The following is a description of a gene set: from publication Chen Y, Wang X (PMID 31504780) Genes predicted to be targets of miRBase v22 microRNA mmu_miR_153_3p in miRDB v6.0 with MirTarget v4 prediction scores > 80 (high confidence targets). Mouse Gene Set: MIR_153_3P species: Mus musculus, and this is the list of marker genes: Sphk2, Taf5, Dmd, Pou4f1, Mdn1, Fhip1a (FHF complex subunit HOOK interacting protein 1A), Smpdl3a, Gatm, Smarca5, Gnpda2, Spty2d1, Rpl22, Nfia, Trp53inp1, Ankrd40, Clgn, Garem1, Nudt4, Zfp704, Nptn, Wwp1, Inhbb, Cbfb (NCBI Gene Id 12400), Ptpn3, Fam168a (family with sequence similarity 168, member A), Kmt2b, Kansl1l, Kmt2a, Rock1, Acap3, Zfp385c, Clcn5, Lamp1, Niban2, Dennd1b, Ttn, Nfe2l2, Ror1, Frmd5, Sptbn4, Ahr, Kdm6a, Eeig1, Gnai3, Celf6, Rttn, Appl1, Gab1, Ube2k, Snai1, Socs2, Ing2, Zhx1, Ddit4, Neurod1, Or4n5, Ago1, Lamc1, Kcnq4, Gmcl1, Fam168b, Nhsl3, Zfp521, Mov10, Ckap4, Pclo, Grb2, Vamp2, Trp53inp2 (transformation related protein 53 inducible nuclear protein 2), Zfp654, Atad2b, Tes, Robo2, Cap1, Mosmo, Sun2, Ctdspl2, Sco1, Adam23, Kif7, Sbno2, Grip1, D430041D05Rik, Ebf2, Tpk1, Rabgap1, Kcna6, Lhfpl6, Rps6ka5, Atp8a1, Txndc11, Zbtb2, Jag1 (NCBI Gene Id 170642), Sigmar1, Rest, Cacna1b, Ybx1, Kcna1, Kctd5, Foxd1, Ski, Zdhhc2, Atosa, Gxylt2, Epha4, Ptbp1, Dcaf12, Me1, Tagln3, Zcchc2 (zinc finger, CCHC domain containing 2), Gm527, Daam1, Fam210b, Fyn, Rps6kb1, Osbpl6 (NCBI Gene Id 99031), Sgms2, Slc4a4, Foxo1, Ttc28, 1600012H06Rik, Rab12, C2cd2, Mknk2, Hgsnat, Lhx9, Arl13b, Six4, Satb1, Fzd3, Actn4 (NCBI Gene Id 97354), Ppm1d, Neurod6, Amph, Otx2 (NCBI Gene Id 218991), Ube2w, Tor1aip1, Casp12, Arid1a, Fbxo33, Sertad2, Sestd1, Unc5c, Fam184b, Utrn (NCBI Gene Id 22288), D030056L22Rik, Iffo2, Bag4, Bsn, Cadm2, Nav2, Cnn3, Cmc4, Dipk1c, Crot, Pax2, Rasa1, Rictor, Cyp1b1, Septin8, Bptf (bromodomain PHD finger transcription factor), Itgb6, Mon2, Zfp950, Scn3a, Tnrc6b, Ttyh3, Ero1b, Dach1, Kdsr, Kctd9, Nek9, Ncoa2, Mitf, Ss18, Yipf2 (NCBI Gene Id 74766), Nfic, Htr1f, Zdhhc1, Adam19, Smarcd2, Efcab7 (EF-hand calcium binding domain 7), Otud4, Mycbp, Mfap3l, Rai14, Desi2, Apc (APC, WNT signaling pathway regulator), Sgk3, Itsn2, Tesk2, Apbb2, Adgra2, Iqck, Morc3, Socs5, Gfpt2, Zcchc14, Cmip, Tpcn1, Nfatc2, Mtf1, Ccdc50, Far1, Lrrc57, Rbak (NCBI Gene Id 57782), Piga, Gpr158, Otud7b, Ank1, Vwa5b2, Nfatc3, Kcnd1, Glce, Azin1, Bend4, Zfp316, Map4k5, Nfib, Nrarp, Wdr26, Dot1l, Dlg2, Mbtd1, Galnt7 (polypeptide N-acetylgalactosaminyltransferase 7), Eras, Prdm2, Slco5a1, Ryr3, Tbc1d19, Hey2, 2810459M11Rik, Grip2, Plcb1, Plekha3, Kbtbd8, Cited2, Dpy19l1, Irx2, Tfam, Kctd6, Jarid2, App, Ubfd1, Pik3r1, Bach2